Given this list of marker genes Mt1, Park7, Slc30a1, Slc30a3, Slc11a1 (NCBI Gene Id 18173), Slc30a10, Mt4, Mt3, Muc2, Slc39a8, Abcb6, Atp7a, Mt2, here is a description of the gene set: Mouse Gene Set: GOBP_STRESS_RESPONSE_TO_METAL_ION Any process that results in a change in state or activity of a cell or an organism (in terms of movement, secretion, enzyme production, gene expression, etc.) as a result of a disturbance in organismal or cellular homeostasis caused by a metal ion stimulus. species: Mus musculus